Given this list of marker genes Hoxc9, Gm4544, Gm36246, Sp7, Gm9108, Gtsf2, Gpr84, Sp1, Atf7, Gm28047, Prr13, Rpl39-ps, Nckap1l, Amhr2, Aaas, Mucl2, Gm9918, 5730585A16Rik, Pde1b, Atp5mc2, Gtsf1, Gm25141, Tarbp2, Mir688, Zfp385a, Pfdn5, Myg1, Hnrnpa1, Cbx5, Itga5, D930007P13Rik, Smug1, Calcoco1, Hoxc10, Mfsd5, Hoxc4, Gm10830, Copz1, Glycam1, Mir196a-2, Hoxc12, Map3k12, Mir6963, Itgb7, Nfe2, Rarg, Npff, Mucl1, Gm28876, Ppp1r1a, Hotair, Gm24128, Mir615, Gm36560, Hoxc6, Pcbp2, Gm21178, Hoxc11, Hoxc5, Hoxc13, Hoxc8, Espl1, Mir148b, here is a description of the gene set: Mouse Gene Set: chr15F3 species: Mus musculus